Given this list of marker genes Krtap31-3, Col6a5, Dok5, Lipk, Krtap19-4, Krtap10-4, Krtap4-16, Krtap5-26, Dpysl5, Sema3a, Rdx, Ncor2, Lgi1, Krtap6-5, Krtap19-2, Ntn4, Krtap13, Krtap6-7, Tubb6, Krt77, Ncam1, Efna2, Artn, Krtap13-22, St8sia4, Arpc2, Cdk5, Krt32, Ap2s1, Cdk4, Krtap10-29, Mmp2, Ap2b1, Rara, Mapk12, Krtap9-21, Krt40, Rasa1, Fes, Krt13, St8sia2, Dok1, Stfa2, Krtap2-22 (NCBI Gene Id 100041412), Efnb3, Rptn, Plxna3 (NCBI Gene Id 18846), Tln1, Krt26, Krtap2-20, Krtap1-4, Tfap2a, Cdkn1a, Krt18, Krt86, Krtap4-26, Krtap16-3, Kit, Krtap12-23, Prkaca, Ap2m1, Cdc42, Tubb4b, Krtap9-22, Krtap9-5, Cdon, Krt17 (keratin 17), Rhob, Krt27, Ephb1, Kitl, Lipm, Sin3a, Krtap4-22, Tchh, Tuba3b, Krt24, Krt73, Krt82, Krtap5-5, Krtap13-21, Arhgef7, Cdh15, Xpo1, Pfn1 (NCBI Gene Id 18643), Krtap4-9, Nrtn (neurturin), Sox10, Shc1, Krtap5-2, Sytl2, Dsg1a, Krt14, Krtap10-28, Krtap12-21, Prkca, Pip5k1c, Krtap4-13, Spink6 (serine peptidase inhibitor, Kazal type 6), Actr3, Prkacb, Ptk2, Tubal3, Krtap19-3, Tuba1a, Tuba8, Lgi4, Sdcbp, Nfasc, Krtap6-1, Ephb2, Tcf7, Efnb1, Krt81, Dok2, Tuba4a, Vasp, Rras, Adam11, Krtap4-23, Sumo1, Krtap5-4 (NCBI Gene Id 50775), Dag1, Krtap10-23, Krtap5-25, Pparg, Ranbp9, Mapk3, Kazn, Hint1, Fgfr1, Dpysl2, Tnfsf11, Tubb4a, Krtap10-27, Qars1, Myrip, Krtap10-25, Crmp1, Plxnd1, Actr2, Spink5, Yes1, Tcf3, Stfa2l1, Wnt3a, Krt20, Dsc2, Cdh2, Stx1a, Rps27a, Krtap5-23, Itga5, Krtap12-22, Psenen, Gfra1, Col6a6, Efnb2, Krt15, Efna5, Krt31, Krtap4-21, Pak3, Krt19, Krt33a, Dsg3, Ephb4, Trem2 (NCBI Gene Id 83433), Ank1, Krtap13-20, Krtap12-20, Arhgef12, Shc3, Reln, Krtap31-2, Fyn, Cacng3, Krt76, Cela2a, Jup, Tuba1b, Hdac3, Tuba1c, Krtap4-6, Krtap10-34, Ngef, Gm5414, Dnm2, Krtap2-4, Gfra2, Col4a2, Krtap10-10, Cebpa, Ptpra, Krtap9-20, Krtap19-5, Sprr3, Col6a1, Krtap1-3, Kars1, Krt28, Krtap4-20, Ubb, Evpl, Sptbn2, Cd72, Smad3, Aimp2, Krt83, Itga2b, Klk14, Cdsn (NCBI Gene Id 386463), Myog, Arpc4, Krt84, Krt4, Erbb2, Ret, Ap2a1, Mapk7, Krt79, Krt16, Lypla2, Gab1, Mapk14, Dsg4, Cacng4, Krtap4-2, Cxcr4, Myod1, Klk8, Irs2, Frs2, Hras, Klk12, Krtap1-5, Arpc5, Krtap5-1, Rps6ka5, Tyrobp, Lipn, Vldlr, Dok4, Lgi2, Efna4, Krt25, Col2a1, Krtap4-8, Krt87 (keratin 87), Ptprc, Grb2, Krtap29-1, Krt8, Ctnnb1, Epha7, Krtap3-1, Krt80, Krtap10-30, Grin1, Shank3, Myf6, Rnd1, Pfn2, Tcf7l1, Egfr, Ep300, Sptbn4, Map2k2, Epha2, Sirt1, Krtap20-21, Pik3cb, Krt33b, Itsn1, Krtap9-3, Ephb3, Krtap3-2, Gdnf, Pik3r2, Krt39, Klk5, Krtap13-1 (keratin associated protein 13-1), Casp14, Evl (Ena-vasodilator stimulated phosphoprotein), Col5a3, Tcf7l2, Dlg4, Krtap9-1, Csnk2b, Krtap3-3 (NCBI Gene Id 66380), Cxcl12, Mitf, Gap43, Krtap4-7, Krt35, Krt36, Krtap6-6, Krtap10-33, Mapk11, Krtap8-1, Col9a1, Lgi3, Map2k1, Sema4d, Psen1, Eef1e1, Grin2b, Krtap31-1, Numb, Ppl, Krt23, Ephb6, Krt71, Dpysl3, Tubb2b, here is a description of the gene set: electronically inferred by orthology from the curated human pathway This event has been computationally inferred from an event that has been demonstrated in another species.<p>The inference is based on the homology mapping from PANTHER. Briefly, reactions for which all involved PhysicalEntities (in input, output and catalyst) have a mapped orthologue/paralogue (for complexes at least 75% of components must have a mapping) are inferred to the other species. Reactome Pathway: Developmental Biology studied in species Mus musculus